Given this list of marker genes Lamp1, Raet1e, Klri1, Ulbp1, Serpinb9d, Klre1, Gimap5, Gfer, Klrb1c, Sh2d1b1, Vav1 (NCBI Gene Id 22324), Crk, Sh2d1a, Lep, Clec2d, Dpp4, Clec12b, Klrc3, H2-M3, Klrd1, Igf2, Inpp5d, Klrc1, H2-T23, Sh2d1b2, Raet1d, Serpinb9b, Ap1g1, Stat5b, Arrb2, Lag3, Serpinb9f, Il12a, Cd226, Lgals9, Serpinb9h, Il12b, Ncr3-ps, Klrb1b, Calhm6, Havcr2, Clnk, Cadm1, Il21, Tgfb1, Rasgrp1, Serpinb9c, Serpinb9g, Klrb1, Rasgrp4, Mill1, Klrk1, Pik3r6, Il18rap (interleukin 18 receptor accessory protein), Tap2, Crtam (NCBI Gene Id 54698), Ceacam1, Slamf6, Grb2 (NCBI Gene Id 14784), Klrb1a, Klrb1f, Stat5a, Nectin4 (nectin cell adhesion molecule 4), Gimap3, Klri2, Nectin2, Tap1, Serpinb9e, Cd96, Pvr, Klrc2, Serpinb9, Cd160, here is a description of the gene set: studied in species Mus musculus Mouse Gene Set: GOBP_REGULATION_OF_NATURAL_KILLER_CELL_MEDIATED_IMMUNITY Any process that modulates the frequency, rate, or extent of natural killer cell mediated immunity.